Given this list of marker genes ZC3H8, MED26, DIPK2A, ZFP64, ORC5, TAP1, CLASP2, LCMT1, NARF, NPRL2, HLX, ZNF532 (zinc finger protein 532), ZMAT3, ENDOG, ZFP1, HHEX, HAUS3, DCTN2, IRF2, CIPC, RPAP3, ABCA4, FAIM, HMCES, CFAP97, DDT, ALAD, YWHAZ, NCOA6, TOR3A (torsin family 3 member A), LGALS9B, SALL3, FNTA, MRPS23, PIK3R4, ERAP1, UROS, IFFO1, ACVR1, RPRD2, SLC37A1, SELE, OTULIN, APOB, ARPC5L, TFB2M, MAP2K4, TNRC6B, TIMELESS, SURF6, MANBA, AAGAB, CHST12, MED9, ACADVL, ABCG8, FERRY3, RFWD3, ZP3, RCC1L, TMPRSS3, UBAC2, ZBTB14, TRMT1, QTRT2, NUF2, COG8, ZNF276, DUT, ERGIC3, FOXJ2, INSM2, REXO4, UCHL5, AMFR, MTFR2, PLAU, MIS18BP1, ABCD2, SLC37A3, NAXE, PCGF6, TMEM106A, INTS5, C19orf12 (chromosome 19 open reading frame 12), CD5L, SOCS6, ZNF426, PITPNC1, LAMTOR1 (late endosomal/lysosomal adaptor, MAPK and MTOR activator 1), TMEM208, TSPAN15, SESN1, ACOX1, OMA1, EPDR1, TMEM63A (NCBI Gene Id 9725), ARHGAP21, CNTNAP4, PSMB9, SH2D1B, MIGA2, ZYG11B, SNORC, ZXDC, CLASRP, OAS2 (2'-5'-oligoadenylate synthetase 2), FBXL12, TMEM51, NSMF, P2RY6, MRPL43, MYO1F, SIGIRR, OSBPL2, PBXIP1, CNOT6, ANGPTL4, RCC2, TRAPPC1, POLD1, IMMP1L, GNE, ZCCHC3, DIDO1, FAM117A, TEX2, TMEM101, SOBP, SRCAP, ACAT1, PIP4P2, ARL6IP4, TAF6, ABHD10, PIGH, SNHG8, ZNHIT2, MICAL1, IL18, APRT, RAD17, GTF3C2, AFG2A, ADAM21, ENTPD4, MTCH1, RRM2B, FBXO25, MSN (moesin), SYNPO, TSTD1, DLX3, COA6, G3BP2, FAM149B1, EMP1, C14orf119 (NCBI Gene Id 55017), CYB5R1, SNX2, UBFD1, BACH1, VHL, MCM7, TRIM25, NECAP1, ACOT8, FAM76B, ACER1, TFCP2, TCTN3, DHX8, GPS1, BAZ2A, EIF4EBP2, PMEL, TMA7, HNRNPD, NAP1L2, METTL23, CCKBR, NCOA1, SLC4A8, TBC1D14, FAAP20, MAP3K3, UBE3B, SLC25A39, KIF1C, PTPN21, CCAR2, RPS15A, CASP9, IFT70B, ZDHHC12, NANP, PALD1, MRPS24, UBE2R2, here is a description of the gene set: mouse primary BMDCs were stimulated with tlr ligands and gene expression changes were profiled on Affymetrix arrays Genes up-regulated in comparison of control dendritic cells (DC) at 2 h versus those stimulated with Pam3Csk4 (TLR1/2 agonist) at 2 h. species: Homo sapiens Human Gene Set: GSE17721_CTRL_VS_PAM3CSK4_2H_BMDC_UP from publication Amit I, Garber M, Chevrier N, Leite AP, Donner Y, Eisenhaure T, Guttman M, Grenier JK, Li W, Zuk O, Schubert LA, Birditt B, Shay T, Goren A, Zhang X, Smith Z, Deering R, McDonald RC, Cabili M, Bernstein BE, Rinn JL, Meissner A, Root DE, Hacohen N, Regev A (PMID 19729616)